Given this list of marker genes IL10, IL10RA, LILRB1, LILRB4, IL10RB, STAT3, JAK1, LILRA1, LILRA2, TYK2, LILRB2, LILRA3, here is a description of the gene set: Human Gene Set: GOBP_INTERLEUKIN_10_MEDIATED_SIGNALING_PATHWAY studied in species Homo sapiens The series of molecular signals initiated by interleukin-10 binding to its receptor on the surface of a target cell, and ending with the regulation of a downstream cellular process, e.g. transcription.